Given this list of marker genes GTF2A1 (general transcription factor IIA subunit 1), SDF2, GPI, LONP1, HMGCS1, ZDHHC5, ING1, TWSG1, MALT1, RNFT1, RBPJ, TNFAIP3, PNRC1, INTS13, MTCH2, TBC1D2, PPIL4, RELT, G3BP2, TFG, RRAGD, PPP1R15B, SLC44A4, UPF3B, TPI1, GRINA, ERO1A, IRAK3, RBBP8, BIRC3, TAF9B, LRP5L, YEATS2, ATF2, NFKBIA, SZRD1, PTS (6-pyruvoyltetrahydropterin synthase), EIF2AK3, NDUFA5, WBP11, ATG9A, NR4A1, DIAPH1, OSM, WDR45B, OXSR1, SPAG4, AKIRIN2, P4HB, CD69, WDR33, AP3S1, ENSG00000291149, ZNF654, EIF4A3, SERTAD3, ZNF674-AS1, PSMC6, ZNF395, BRAF, PTGER4, KDM5B, PTGES3, SLC43A3, SF3A1, CEP95, KDM3A, TRAF3, LIF, DHX40, FAM50A, USP28, ELL2, MAPK1IP1L, NGLY1, ZMYM2, DBF4 (NCBI Gene Id 10926), SAFB, NR4A3, GPR160, NUP98, PSMA6, ANXA11, DENND5A, RTL8C, CDK2, GADD45B, FFAR3, PRDX4, MAP1LC3B, SNX3, AK2, PDXK, CLDND1, LPCAT1, CDC26, GABARAPL2, CREB3, RXRA, CD63, GOLGA1, CFAP36, ICAM1, EMD, SPAG9, HSPA13, NFKBIE, MEA1, FNTA, CAPN7, DIPK2A, SFXN3, MAPK6, EDN1, ADPGK, OLR1, NUMA1, NPC1, CYSTM1, PGAM1, AK4 (adenylate kinase 4), CISD2, IPMK, CCNK, SERPINE1, JOSD1, CCDC93, GLUL, TRIB1, MAP2K1, RAB21, BCL3, GGTLC1, PPP1R2, GNA15, CSNK1A1, TTC21A, TMCO3, SLC3A2, TBC1D15 (NCBI Gene Id 64786), RABGEF1, FBXO42, GPR35, DNAJB9, CRY1, GLA, PIK3CB, SCYL2, HNRNPU, EXOSC4, RYBP, ARHGDIA (NCBI Gene Id 396), TM9SF3, SH3BP5, LNPK, ZEB2, NFE2L2, TMEM268, NARF, MORF4L2, INTS6L, FGFR1OP2 (FGFR1 oncogene partner 2), DDX50, SGF29, IGBP1, BZW1, TPRA1, LAMTOR3, RAB9A, TMEM140, AP3S2, ZNF277, IRAK2, SLC36A4, NSMCE2, IFNGR2, ZHX2, CXCL2, GTPBP2, HPCAL1, RAB8B, SNHG12, SEC61G, ADIPOR2, ZNF292, FKBP15, ETF1, CHMP4B, ALKBH5, DEDD2, CBFA2T2, PCF11, ARL5B, HPS5, PIK3IP1, VDAC1, PCBP1, FCRLB, GPBP1L1, TANC2, here is a description of the gene set: We demonstrated recently that both constitutive and FAS-triggered apoptosis of human neutrophils are profoundly impaired by Francisella tularensis, but how this is achieved is largely unknown. To test the hypothesis that changes in neutrophil gene expression contribute to this phenotype, we used human oligonucleotide microarrays to identify differentially regulated genes in cells infected with F. tularensis strain LVS compared with uninfected controls. In order to examine the effect of F. tularensis on the neutrophil transcriptome, we performed microarray expression analysis on human neutrophils treated with F. tularensis subsp. holarctica live vaccine strain (LVS). studied in species Homo sapiens Human Gene Set: GSE37416_CTRL_VS_24H_F_TULARENSIS_LVS_NEUTROPHIL_DN Genes down-regulated in comparison of control polymorphonuclear leukocytes (PMN) at 24 h versus PMN treated with F. tularensis vaccine at 24 h. from publication Schwartz JT, Bandyopadhyay S, Kobayashi SD, McCracken J, Whitney AR, Deleo FR, Allen LA (PMID 22986450)